Given this list of marker genes KANK1, SNX2, CORO1C, RREB1, CD44, WASF1, ENPP2, VIL1, SNX1, WASF2 (NCBI Gene Id 10163), CORO1B, PLEKHO1, PDPN (NCBI Gene Id 29912), ARHGEF7, ARPIN, MYO9B, ABI1, SRC, here is a description of the gene set: studied in species Homo sapiens Human Gene Set: GOBP_LAMELLIPODIUM_MORPHOGENESIS A process that is carried out at the cellular level and in which the structure of a lamellipodium is organized.